The following is a description of a gene set: studied in species Mus musculus part of: Chaperonin-mediated protein folding electronically inferred by orthology from the curated human pathway This event has been computationally inferred from an event that has been demonstrated in another species.<p>The inference is based on the homology mapping from PANTHER. Briefly, reactions for which all involved PhysicalEntities (in input, output and catalyst) have a mapped orthologue/paralogue (for complexes at least 75% of components must have a mapping) are inferred to the other species. Reactome Pathway: Association of TriC/CCT with target proteins during biosynthesis, and this is the list of marker genes: Cct2, Cct6b, Cct8, Cct7, Cct5, Cct3, Cct6a